The following is a description of a gene set: Human Gene Set: MIR199A_3P_MIR199B_3P Genes predicted to be targets of miRBase v22 microRNA hsa-miR-199a-3p, hsa-miR-199b-3p in miRDB v6.0 with MirTarget v4 prediction scores > 80 (high confidence targets). from publication Chen Y, Wang X (PMID 31504780) studied in species Homo sapiens, and this is the list of marker genes: ZHX1, NACC1, FGF7, GRK3, CDK17 (cyclin dependent kinase 17), RFX3, ITGA8, ITGA3, SDC2, GNA12, CDNF, CYP1B1, MAP3K2, ETNK1, NOVA1, AMZ2, TMEM62, MS4A7, ANKRD44, RP1, ATAD1, APLP2, DEPDC1B, ASAP2, PLEKHH1, TUBGCP3, ADAMTSL3, PLCB1 (phospholipase C beta 1), SCD, PHLPP2, PTPRC, IFFO2, KIAA0319L, ITGB8, ARL15, TBX3, CXADR, KDM6A, AK4, RAPH1, CREBRF, MVB12B, RUNX1, UBQLN1, PNRC1, SINHCAF, HIC2, ADD3, KDM5A, GORAB, PROSER1, ZNF217, PPP2R5E, GALNT7, ATRX, PAWR, WDR47, BCAR3, RB1, LPAR4, RBM47, SLC20A2, ANKRD61, EPG5, LAMP3, KATNBL1, CCDC85C, ERBB4, SLITRK6, MED12L, CHAD, CSRP2, MPP7, FUBP1, TGIF2, ESRP1, ITGA6, C9orf40, APLF, NTRK2, DNHD1, CELSR2, RAP2A, MCFD2, ADAM10, CDK7, RPS6KA6, SH3GLB1, MAP3K4, NIBAN1, WFDC8 (WAP four-disulfide core domain 8), PON2, SOS2, LRP2, PCDH7, PIK3CB (phosphatidylinositol-4,5-bisphosphate 3-kinase catalytic subunit beta), NET1, NID2, TAB2, ACVR2A (activin A receptor type 2A), SMIM8, C2orf49, ADRB1, SLC24A2, QKI, PTPN3, NEDD4, NECTIN2, ALX4, FN1, KLHL3, PAK4, CYB5R4, PSD2, SLC39A10, CBLL1, CD2AP, TAOK1 (TAO kinase 1), PTPRZ1, LIN28B (NCBI Gene Id 389421), AEBP2, EMC1, G3BP2, NLRP1, MECP2, KDM3A, COL12A1, PLAG1, DCBLD2, MAP3K5, PDE4B, CPEB4, ARHGEF3, LRRC1, TPPP, DNMT3A, PRPF40A (NCBI Gene Id 55660), PPP4R2, VAMP3, SEMA3A, ITPK1, ADAMTS3, NAA25, SP1, SLC44A5, ACVR2B, FXR1, NLK, EBF1 (EBF transcription factor 1), CTNNA2, FAM199X, SERPINE2, VPS33A, CEP85L, LLGL2